The following is a description of a gene set: Genes up-regulated in CD4 T cells activated by anti-CD3 and anti-CD28: TGFB1 and IL-12 (48h) versus IL4 (48h). Th1 and Th2 cells arise from a common precursor cell in response to triggering through the TCR and cytokine receptors for IL-12 or IL-4. This leads to activation of complex signaling pathways, which are not known in detail. Disturbances in the balance between type 1 and type 2 responses can lead to certain immune-mediated diseases. Thus, it is important to understand how Th1 and Th2 cells are generated. To clarify the mechanisms as to how IL-12 and IL-4 induce Th1 and Th2 differentiation and how TGF-beta can inhibit this process, we have used oligonucleotide arrays to examine the early polarization of Th1 and Th2 cells in the presence and absence of TGF-beta after 0, 2, 6 and 48 hours of polarization. Human Gene Set: GSE2770_IL12_AND_TGFB_VS_IL4_TREATED_ACT_CD4_TCELL_48H_UP studied in species Homo sapiens from publication Lund R, Aittokallio T, Nevalainen O, Lahesmaa R (PMID 14607935), and this is the list of marker genes: AKNA, XAF1, SCPEP1, TXLNG, FCGRT, SETD4, TASL, RASGEF1B, POGLUT1, PTGER1 (prostaglandin E receptor 1), SNX19, HSD17B11, SIGIRR, PTPN14, ORAI1, ETV3, MCOLN2, MMAA, KCTD6, SMPDL3A, ARRB1, APBB3, GPATCH2, BST2, PLEC, P2RY10, HIPK2, MYO1C, DYRK2, ANXA9, MPP1, UBR1, SPAG9, SOCS3, TXNRD3, SH2D2A, TSPAN32, GSDMD, ANGEL1, CDC42EP4, COMMD3, C1orf54, GOLM1, ANKIB1, USP4, ACVR1B, RIPOR1, COLGALT1, PINK1, QPRT, HERPUD2, STOML1, APEH, SH3BP2, LSP1, GSAP, ARID4A, AMBRA1, ITPK1, MEIS3, HLA-DOB, PPCDC, ESRP2, ZBTB10, ARPC5, DENND6B, TNFRSF1B, ATG4D, OSGIN1, TSPO, CNRIP1, CFAP96, PCYT1A, DNAH17, ARID5A, CHST12, KLF4, ACY1, HLA-DOA, MX2, GLIPR2, PPARGC1B, DNAJA4, ZNF878, REC8, ALPK2, DIXDC1, FAM241A (NCBI Gene Id 132720), PBXIP1, IP6K1, KLHL15, PAXBP1, CARD11, DGKD, INPP5F, ZFP36L1, RELCH, PCP4, COQ10B, FLI1, INCA1, SLC49A4 (solute carrier family 49 member 4), MGAT5, TAPBP (NCBI Gene Id 6892), RBPJ, TK2 (NCBI Gene Id 7084), ACAP2, S1PR1 (sphingosine-1-phosphate receptor 1), ZFP28, CD72, GBP7, TRIM24, NFATC2, SLC29A4, CYB561A3 (cytochrome b561 family member A3), MFN1, KLF13, VPS37B, IFI27, PPP3CA, NUCB2, RELA, TCEA2, RNF138, TNRC6C, PRKCE, KCTD12, TSPAN31, ARV1, RNF123, SLC12A6, AKT3, IRF9, SRMS, APOLD1, PREX1, MAP4K2, METAP1D, RNF167, FCHO2, STK38, STARD10, GRAMD1A, B4GALT5, VPS13D, ZC3H12A, IQSEC1, ZNF398, CRLF2, CERS4, IL6R, PDE1B, CD2, UNC119 (NCBI Gene Id 9094), ATP13A2, RHOF, FBXL20, IL10RB, AZI2, NUFIP2, DAD1 (NCBI Gene Id 1603), TRIP11, ABHD17B, CDK10, TCF4, PATJ, CFP, CLCN5, CAPN7, EMP3, PTPN6, EVI5L, POLR3A, AVL9, CDS2, HUWE1, TATDN3, AFP, IPCEF1, PDE8A, TIPARP, ATP10D, ZNRF1, RFTN2, TRIM7, DENND2D, DNASE1L3, FAM210B, TOM1L2, SEMA4F, ANKRD44, SRGAP3, SNORD123, TEP1, PLBD1, HPS1, PLXNC1, MTAP, STAT6, PDK2